Given this list of marker genes P2RX4, EPS8L3, STAP1, COBL, CORO1C, PFN2, ARF6, PIP5K1A, KANK1, FAM98A, TPM1, USP17L2, CORO1B, AIF1L, P2RY12, EPS8, LIMA1, ABI3, ARHGEF26, SNX10, EPS8L2, DEF8, STON1, RDX, INPPL1, MTOR, PLEK, INPP5K, ICAM1, CCL21, SH3YL1, CARMIL2, NLGN1, CCR7, EPS8L1, CARMIL1, RAC1, AIF1, PFN1, CAV1, WDPCP, EVL, CSF1R, TACSTD2, CSPG4, SH3BP1, ARHGAP24, ARFIP2, TCIRG1, BAG4, PLEKHA1, HRAS, RCC2, CYFIP1, RHOG, NDEL1, PLEKHM1, here is a description of the gene set: species: Homo sapiens Human Gene Set: GOBP_RUFFLE_ORGANIZATION A process that is carried out at the cellular level which results in the assembly, arrangement of constituent parts, or disassembly of a ruffle, a projection at the leading edge of a crawling cell.